Given this list of marker genes IQGAP3, MYH8, SPATA6 (spermatogenesis associated 6), MYOC, MYO19, MYLK2, CXCR4, SPATA6L, here is a description of the gene set: Human Gene Set: GOMF_MYOSIN_LIGHT_CHAIN_BINDING species: Homo sapiens Binding to a light chain of a myosin complex.